Given this list of marker genes THRB, ARMC8 (NCBI Gene Id 29067), ABHD15, ZHX3, TRDMT1, TOMM22, ANKFY1, RTKN2, STAG2, NCOA7, FYTTD1, NSD2, ACTR3, KSR2 (NCBI Gene Id 341537), EIF4G2, SHOC2, E2F7, SORBS2, KCNQ5, ZNF366, WNK1, CYP4X1, NHSL3, PDLIM5, GGA3, ZC3H12C, GOLM2 (golgi membrane protein 2), ACTR1B, ZBTB9, DENND11, PACSIN3, WAPL, UPK1B, ADGRL3, NFATC1, PROX1, NKAPD1 (NCBI Gene Id 55216), NCBP1, IGDCC4, L2HGDH, STXBP5L, SLC25A24, UBE2D1, RFX2, FZD4 (frizzled class receptor 4), TMEM120B, ZNF37A, CDIN1, TMEM179, CAV3, ANKRD34A, RAB5B, ARB2A (NCBI Gene Id 83989), SEMA4F, PATZ1, ATP10D, RAP2A, OTUD3, RAD9A (NCBI Gene Id 5883), here is a description of the gene set: from publication Chen Y, Wang X (PMID 31504780) species: Homo sapiens Human Gene Set: MIR3127_5P Genes predicted to be targets of miRBase v22 microRNA hsa-miR-3127-5p in miRDB v6.0 with MirTarget v4 prediction scores > 80 (high confidence targets).